Given this list of marker genes Lrrc8e, Lrrc8b, Slc46a2, Abcc4, Lrrc8c, Lrrc8a, Abcc1 (ATP-binding cassette, sub-family C member 1), Abcc5, Lrrc8d, Shoc2 (NCBI Gene Id 56392), Slc19a1, here is a description of the gene set: The directed movement of a cyclic nucleotide, any nucleotide in which phosphate group is in diester linkage to two positions on the sugar residue, into, out of or within a cell. species: Mus musculus Mouse Gene Set: GOBP_CYCLIC_NUCLEOTIDE_TRANSPORT